The following is a description of a gene set: Migraine with aura A type of migraine in which there is an aura characterized by focal neurological phenomena that usually proceed, but may accompany or occur in the absence of, the headache. The symptoms of an aura may include fully reversible visual, sensory, and speech symptoms but not motor weakness. Visual symptoms may include flickering lights, spots and lines and/or loss of vision and/or unilateral sensory symptoms such as paresthesias or numbness. At least one of the symptoms of an aura develops gradually over 5 or more minutes and/or different symptoms occur in succession. studied in species Homo sapiens Human Gene Set: HP_MIGRAINE_WITH_AURA, and this is the list of marker genes: COL4A1, CACNA1A, KCNK18, TNF, TREX1, NOTCH3, SCN1A, CSNK1D, PRRT2, ATP1A2, EDNRA, ESR1